The following is a description of a gene set: Human Gene Set: HP_LONG_PALM Long palm species: Homo sapiens For children from birth to 16 years of age the length of the palm is more than the 97th centile; or, the length of the palm appears relatively long compared to the finger length or the limb length., and this is the list of marker genes: UPF3B, SMS, SLC2A10, POR, UBE3B